Given this list of marker genes TNNT2, SCN3B, AKAP9, RYR1, KCNE3, RANGRF, GYG1, PRKAG2, KCND3, CACNA2D1, SCN1B, TRPM4, KCNJ8, TBX20, GATA4, HCN4, KCNE5, SCN10A, SCN5A, NKX2-5, GPD1L, CITED2, CACNB2, SCN2B, CLCNKB, GATA6, ABCC9, POLG, SCNN1A, ACTC1, SLC12A3, MYH6 (NCBI Gene Id 4624), PKP2, SLMAP, SEMA3A, RAF1, TNNC1, TLL1, CACNA1C, here is a description of the gene set: An electrocardiographic anomaly of the ST segment, which is the segment that connects the QRS complex and the T wave. The ST segment normally has a duration of 80 to 120 ms, is flat and at the same level (isoelectric) as the PR and TP segment. Human Gene Set: HP_ABNORMAL_ST_SEGMENT Abnormal ST segment species: Homo sapiens